Given this list of marker genes Slc26a5, Slc26a1 (solute carrier family 26 (sulfate transporter), member 1), Slc26a11, Slc26a6, Slc26a8, Agxt, Slc26a7, here is a description of the gene set: The directed movement of oxalate into, out of or within a cell, or between cells, by means of some agent such as a transporter or pore. Oxalate, or ethanedioic acid, occurs in many plants and is highly toxic to animals. studied in species Mus musculus Mouse Gene Set: GOBP_OXALATE_TRANSPORT